The following is a description of a gene set: Enables the transmembrane transfer of a potassium ion by an inwardly-rectifying voltage-gated channel. An inwardly rectifying current-voltage relation is one where at any given driving force the inward flow of K+ ions exceeds the outward flow for the opposite driving force. The inward-rectification is due to a voltage-dependent block of the channel pore by a specific ligand or ligands, and as a result the macroscopic conductance depends on the difference between membrane voltage and the K+ equilibrium potential rather than on membrane voltage itself. studied in species Homo sapiens Human Gene Set: GOMF_INWARD_RECTIFIER_POTASSIUM_CHANNEL_ACTIVITY, and this is the list of marker genes: KCNH6, KCNK1, ABCC9, KCNJ8, KCNN1, KCNJ6, KCNJ10, KCNN3, KCNJ2, KCNH3, KCNN2, KCNJ15, KCNJ12, KCNJ16, KCNJ4, KCNJ14, KCNJ9, KCNJ1, KCNJ11, KCNJ18, KCNE2, KCNJ3, CAV1, KCNH2, ABCC8, KCNJ13, KCNK6, KCNJ5, KCNH7